Given this list of marker genes NEUROG3, VPS33B, NOTCH2, PRF1, CCDC115 (NCBI Gene Id 84317), AMACR, DNASE2, EPCAM, UNC13D, YARS1, STXBP2, STX11, HADHA, PERCC1, SHPK, DHCR7, HSD3B7, VIPAS39 (VPS33B interacting protein, apical-basolateral polarity regulator, spe-39 homolog), here is a description of the gene set: Cholestatic liver disease Human Gene Set: HP_CHOLESTATIC_LIVER_DISEASE species: Homo sapiens